Given this list of marker genes Scn4b, Cacna2d3, Catspere2, Akap9, Cacna2d2, Cnga4, Atp5f1d, Kcnh1, Lrrc38, Kcnip1, Scn9a, Atp5f1c, Kcna4, Hcn3, Kcnmb1, Kcna5, Scn1b, Trpc6, Slco6c1, Kcnq1, Dmac2l, Kcna3, Kcna7, Kcnq3, Cacng7, Trpc3, Catsper2, Grik2, Kcnc3, Hcn1, Snap25, Slc5a3, Cacna2d4, Calm2, Kcnj8, mt-Atp6, Kcng2, Kcnv2, Calm1, Cacna1c, C2cd6, Catspere1, Scnn1g, Micu2, Kcng1, Cntnap2, Cacna2d1, Catsperz, Kcnj9, Scn2b, Smdt1, Kcnq4, Atp5mj, Atp5f1b, Kcnmb2, Hcn4, Cacna1b, Kcne2, Scn2a, Cacng4, Atp6-ps, Htr3a, Scnn1b, Scn11a (sodium channel, voltage-gated, type XI, alpha), Kcnc2, Ryr1, Grik1, Kcnq5, Kcnmb4, Stx1a, Ryr2, Pkd2, Fkbp1b, Dlg4, Hcn2, Kcnd3, Pkd2l1, Kcna1, Cacna1d (NCBI Gene Id 97919), mt-Atp8, Tmem262, Kcnd1, Cacnb2, Ryr3, Kcnip4, Kcns2 (K+ voltage-gated channel, subfamily S, 2), Mcu, Kcnh2, Kcne1, Kcne5, Kcns1, Kcne3, Micu1, Kcna10, Cnga1, Trpv6, Htr3b, Amigo1, Kcnh5, Kcnip3, Cttn, Atp5f1a (ATP synthase F1 subunit alpha), Trpc5, Cnga2, Atp5pd, Scnn1a, Cacna1s, Atp5po, Scn8a, Atp5mg, Trpc1, Cnga3, Akap6 (A kinase anchor protein 6), Kcnab2, Kcnj3, Trpm4 (NCBI Gene Id 68667), Trpc2, Kcnk1, Catsper3, Cacna1i, Cacng8, Atg5lrt, Cacng6, Catsper4, Cacng2, Kcna2, Cachd1, Tmem249, Kcnk4, Atp5mc2, Hspa2, Calm3, Catsperg1, Kcnj5, Kcnc4, Sumo1 (small ubiquitin-like modifier 1), Cacng1, Lrrc52, Cacna1h, Cacna1a, Ccdc51, Atp5pf, Grik4, Pkd1, Abcc8 (NCBI Gene Id 330527), Kcnj2, Lrg1, Scn3b, Kcns3, Pex5l, Vamp2, Cacna1g, Dlg2, Dpp10, Kcng3, Grik5, Kcnd2, Kcnmb3, Kcnab3, Kcnip2, Dpp6, Kcnab1, Kcng4, Kcnj6, Atp5mc1, Kcnma1, Kcnj11, Sestd1, Mcub, Pde4d, Kcnk2, Kcne4, Cacnb1, Scn5a, Kcnq2, Unc80, Catsperg2, Cacnb4, Efcab9, Pkd1l1, Lrrc26, Grik3, Cacna1f, Cngb1, Atp5pb, Catsper1, Gria4, Trpc7, Kcnc1, Fkbp1a, Atp5mk, Trpc4, Scn1a, Atp5f1e, Catsperd, Abcb8, Kcnv1, Micu3, Atp5me, Abcc9, Cngb3, Kcna6 (potassium voltage-gated channel, shaker-related, subfamily, member 6), Cacna1e, Ptpa, Kcnf1, Atp5mf, Stac3, Kcnb1, Scn10a, Trpv5, Pkd1l3, Cacnb3, Lrrc55, Kcnb2, Scn4a, Catsperb, Scn3a, Trdn, Atp5mc3, here is a description of the gene set: Mouse Gene Set: GOCC_CATION_CHANNEL_COMPLEX species: Mus musculus An ion channel complex through which cations pass.